The following is a description of a gene set: species: Homo sapiens Human Gene Set: PID_HIF1_TFPATHWAY HIF-1-alpha transcription factor network from publication Schaefer CF, Anthony K, Krupa S, Buchoff J, Day M, Hannay T, Buetow KH (PMID 18832364), and this is the list of marker genes: NOS2, EPO, FURIN, CITED2, EDN1, RORA, TFF3, CP, FOS (NCBI Gene Id 2353), ARNT, EGLN1, HK2, CA9, SLC2A1, TERT, ETS1, SP1, GCK, NCOA1, BHLHE40, NDRG1, FECH, HMOX1, GATA2, IGFBP1, LDHA, VEGFA, HDAC7, COPS5, ENO1, HK1, JUN, PLIN2, PGK1, CREBBP, PFKFB3 (6-phosphofructo-2-kinase/fructose-2,6-biphosphatase 3), PKM, MCL1, SMAD4, BHLHE41, NPM1, CREB1, ID2, CXCR4, TF, AKT1, LEP, ADM, EP300, PGM1, EGLN3, SMAD3, SERPINE1, ITGB2, ENG, CXCL12, TFRC, PFKL, ALDOA, HIF1A, ABCG2, ABCB1, NCOA2, BNIP3, HNF4A, NT5E (5'-nucleotidase ecto)